Given this list of marker genes Clec4b1, Cx3cr1, Clec4a2, Clec4a3, Defb42, Spi1, Clec4e, Usp15, Fam3a (FAM3 metabolism regulating signaling molecule A), Trim62 (NCBI Gene Id 67525), Clec7a, Clec4a1, Bcl10, Rarres2, Clec4n, Pla2g5, Clec4b2, Clec4a4, Defb19, Card9, Plcg2, Clec4d, here is a description of the gene set: Mouse Gene Set: GOBP_ANTIFUNGAL_INNATE_IMMUNE_RESPONSE An defense response against a fungus mediated through an innate immune response. An innate immune response is mediated by germline encoded components that directly recognize components of potential pathogens. studied in species Mus musculus